Given this list of marker genes PRSS21, SLIT3, KAT2B, CELSR2, RARRES1, OAS3, SEMA3C, INPPL1, EVX1, CHD4, YWHAG, EIF3E, CEMIP2 (NCBI Gene Id 23670), SLCO2B1, SEC22A, LAMA5, SLC25A4, SCN1B, SMG1, BPNT1, AK1, B4GALT5, CYP2D6, FGA, CCPG1, SLC12A4, PDCD4, ICMT, RPP38, XIAP, MAD2L1, HDLBP, PDCD10, TMED9, PWP2, COL4A4, FGG, ADAP1, HSPA6, LSM4, GGH, ROCK1, ACVRL1, WT1, UBE2L6, LY6G5C, CHEK1, CD83, CLEC5A, KRT7, JMJD7-PLA2G4B, NRXN3, KIFC1, FCN3 (ficolin 3), TXNL1, FASN, NEU1, CA3, NUMA1, RNF2, RTCB, BCAP31, USP22, RNF11, DCDC2, SSNA1, BMI1, BCL7A, POLR2L, CDC42, CENPA, CASP1, ELF2, TENT4A, PRKG1, MTHFD1, OXA1L, MAP3K5, FADS3, HERC1, LSP1P4, BMP7, LRRN2, PHKG2, NOMO1, CD81, DPF1, TYROBP (NCBI Gene Id 7305), MRPL23, ZNF330, LY96, ACSM3 (NCBI Gene Id 6296), RAP1GAP, NDUFB5, OLFM1, FYB1, ALDH3B2, LAG3, ARID4A, PLTP, QARS1, MYH9, PEX1, IL1R2, PTPRC, KSR1, GAPDH, TPM2, POLA2, FOLR2, RCVRN, CHN1, RRM2, LHX6, COL2A1, GCGR, AMPD2 (NCBI Gene Id 271), CALB1, PSG2, SRP68, ENKD1, IL10RB-DT, IFI30, PIK3CD, ITIH2, P2RX5, KLRK1, SEC24C, ESRRB, RCN2, RRAD, IL18, CIR1, RBM4, WNT2, RALA, GRM3, ACAA2, SNTB1, PLXNC1, BAG4, SEC23IP (SEC23 interacting protein), PRDX6 (peroxiredoxin 6), IDO1, TLR3, SGK1, IL32, GFM2, HSPA1A, CFDP1, JAG1, SLC31A2, DCT, SSX4, OCRL, GJB5, STXBP2, MATK, CCT4, DUSP4, PRMT1, SNRPE, CAPZB, IKBKE, PDCD2, LAGE3, CFAP45, HOXD9, PEA15, PON3, CNOT9, DUS4L, IRX5, TK1, NELL2, PLK1, ABCB10, PECAM1, INA, PSMA4, SOX30, TRPM1, POSTN, FXR1, MOCS3, PTBP1, HMGCL (NCBI Gene Id 3155), LMO2, BMP2, RRAS2, ALG1, CTSD, LAMP3, TIMM17B (NCBI Gene Id 10245), FKBP1A, TONSL, POLD3, GFRA3, ORC3, ZBTB17, KMT2A, ITPR2, SP110 (SP110 nuclear body protein), IFNGR1, P2RX6, KCNA4, OSTF1, HPCAL1, HSD3B1, MBTPS1, RAP2A, UBA7, CA1, HSPA13, HM13 (NCBI Gene Id 92622), ABCB1 (ATP binding cassette subfamily B member 1), EPB41, MED12, PROS1, OPHN1, LYPLA1, DPYS, MEF2C, DDX11, H2BC21, CXCR6, CHUK, DOK1 (docking protein 1), HERC3, TYK2, SLC16A3, NBL1, ADAM18 (ADAM metallopeptidase domain 18), BDH1 (3-hydroxybutyrate dehydrogenase 1), PSME1, TKT, MANF, CLUL1, POMZP3, IL1R1, HACD3, USP15, RANBP2, TFF2, OXCT1, GHRH (growth hormone releasing hormone), MYOG, MYL12B, SLC26A4, SRRT, HCN4, VDAC1, SORL1, HSD17B8, FGF18, ZFAND5, EHD3, HCCS, PRKCSH, SLC14A1, DDX17, MEST, here is a description of the gene set: A crucial step in human breast cancer progression is the acquisition of invasiveness. There is a distinct lack of human cell culture models to study the transition from preinvasive to invasive phenotype as it may occur spontaneously in vivo. To delineate molecular alterations important for this transition, we isolated human breast epithelial cell lines that showed partial loss of tissue polarity in three-dimensional reconstituted basement membrane cultures. These cells remained noninvasive; however, unlike their nonmalignant counterparts, they exhibited a high propensity to acquire invasiveness through basement membrane in culture. The genomic aberrations and gene expression profiles of the cells in this model showed a high degree of similarity to primary breast tumor profiles. The xenograft tumors formed by the cell lines in three different microenvironments in nude mice displayed metaplastic phenotypes, including squamous and basal characteristics, with invasive cells exhibiting features of higher-grade tumors. To find functionally significant changes in transition from preinvasive to invasive phenotype, we performed attribute profile clustering analysis on the list of genes differentially expressed between preinvasive and invasive cells. We found integral membrane proteins, transcription factors, kinases, transport molecules, and chemokines to be highly represented. In addition, expression of matrix metalloproteinases MMP9, MMP13, MMP15, and MMP17 was up-regulated in the invasive cells. Using small interfering RNA-based approaches, we found these MMPs to be required for the invasive phenotype. This model provides a new tool for dissection of mechanisms by which preinvasive breast cells could acquire invasiveness in a metaplastic context. from publication Rizki A, Weaver VM, Lee SY, Rozenberg GI, Chin K, Myers CA, Bascom JL, Mott JD, Semeiks JR, Grate LR, Mian IS, Borowsky AD, Jensen RA, Idowu MO, Chen F, Chen DJ, Petersen OW, Gray JW, Bissell MJ (PMID 18316601) species: Homo sapiens Human Gene Set: RIZKI_TUMOR_INVASIVENESS_3D_DN Genes down-regulated in three-dimentional (3D) cultures of preinvasive (S3-C) vs invasive (T4-2) breast cancer cells.